The following is a description of a gene set: species: Homo sapiens part of: SLC transporter disorders SLC9A9 encodes the sodium/hydrogen exchanger 9 NHE9 which is expressed ubiquitously and thought to play a housekeeping role in pH homeostasis in the late endosome membrane. A defect in SLC9A9 can contribute to susceptibility to autism 16 (AUTS16; MIM:613410). Autism, the prototypic pervasive developmental disorder (PDD), is a complex, multifactorial disorder characterised by reciprocal social interaction and communication impairment, restricted and stereotyped patterns of interests and activities, and the presence of developmental abnormalities by age 3. Reactome Pathway: Defective SLC9A9 causes autism 16 (AUTS16), and this is the list of marker genes: SLC9A9